The following is a description of a gene set: studied in species Mus musculus Mouse Gene Set: GOMF_PYRIMIDINE_RIBONUCLEOTIDE_BINDING Binding to a pyrimidine ribonucleotide, any compound consisting of a pyrimidine ribonucleoside that is esterified with (ortho)phosphate or an oligophosphate at any hydroxyl group on the ribose moiety., and this is the list of marker genes: Cad, Mtpap, Hsp90ab1, Hsp90aa1, Ugp2